The following is a description of a gene set: species: Mus musculus Mouse Gene Set: REACTOME_MHC_CLASS_II_ANTIGEN_PRESENTATION MHC class II antigen presentation, and this is the list of marker genes: Kif2a, H2-DMb2, Ap1s1, Kif26a, Capza2, Kif26b, Lag3, Dync1i1, Tuba8, Tuba1c, Dync1i2, Sar1b, Ap1m2, H2-DMa, Kif16b, H2-Aa, Actr1a, Kif23, Kif15, Tubb4b, Ctsc, Kif2c, Kifc5b, Ctsd, Dnm2, Sec24a, Tuba1b, Kif28, Kif1b, Kif13b, Dctn6, Kif18b, H2-Ob, Ap2s1, Rab7, Kif4, Canx, Cltc, H2-Eb1, Klc4, Kif11, Tubb1, Tubb2a, Klc2, Dync1h1, Ap2m1, Tubb4a, Kif5b, Ifi30, Ap2b1, H2-DMb1, Tubal3, Ctsf, Dynll1, Kif27, Tubb3, Cd74, Kif3b, H2-Ea, Dctn4, Dynll2, Kif1a, Klc1, Ctso, Ap1b1, Sec24c, Sec23a, BC051665, Capzb, Sec24d, Ctss, Klc3, H2-Ab1, Tubb6, Ctsa, Tubb2b, Ap1g1, H2-Oa, Dync1li2, Dync1li1, Ctsb, Kif22, Kif2b, Osbpl1a, Cenpe, Kif21b, Sec24b, Arf1 (ADP-ribosylation factor 1), Tuba3b, Kif5a, Kif3c, Kif6, Dnm3, Kif21a, Dctn5, Kifap3, Racgap1, Dctn3, Tuba3a, Kif9, Clta, Ap2a1, Sec13, Kif1c, Capza3, Kifc1, Ctsh, Tuba4a, H2-Eb2, Sec31a, Dnm1, Sptbn2, Kif20a, Tuba1a, Ap1m1, Ctse, Dctn1, Ctsl, Kifc2, Kif12, Sh3gl2, Lgmn, Kif3a, Kif20b, Ap2a2, Dctn2, Actr1b, Kif19a, Rilp, Ap1s3, Kif18a, Actr10, Ctsk, Ap1s2